Given this list of marker genes FHL1, CKB, CYTH1, HECA, BABAM2, VEGFA, UCK2, CD55, PLIN2, RNF19A, SINHCAF, RYBP, YWHAH, DBI, PHYH, CYP39A1, ARID1A, ITGA2, INPP5A, SSBP2, CMC4, CH25H, KCNJ12 (potassium inwardly rectifying channel subfamily J member 12), PROS1, GAB2, DIAPH2, PTPRF, NELL2, SHB, RAPGEFL1, LIMA1, DBF4, PACSIN2, TACC2, KAT6B, DSG3, SUCO, ID4 (NCBI Gene Id 3400), GAS6, ZBTB11, SLCO3A1, DCP1A, OPN3, PRC1, E2F6 (NCBI Gene Id 1876), HDAC5, SPTAN1, UNG, DAPK3, SNAI2, DGCR6, OXSR1, HBA1, CSNK2A2, MXD1 (NCBI Gene Id 4084), RNF4, CYP4F12, BCL11B (NCBI Gene Id 64919), TESK2, SLC22A18, CLIC3, PKIA, CHORDC1, CTPS1, GATM, EPHB6, PDGFC, IRF8, PTGS2 (NCBI Gene Id 5743), CYP27B1, PER3, PTPN21, PBXIP1, RHOB, AREG, TDG, RSU1, GAN, EIF4G3, KLF11, SOS2, RAB40B, EML2, GSTA4, PLXNA2, FRY, RLF, SLCO4A1, GALC, TBK1, PITPNB, CUTA (cutA divalent cation tolerance homolog), HSPB1, SMNDC1, ABCD3, BCHE, CPM, LGALS3, EML1 (EMAP like 1), SCARB1, SCEL, CADM1, LEMD3, STXBP1, KLF2, DNASE2, DHX8, SH3GLB2, PTPRA (protein tyrosine phosphatase receptor type A), CXCL14, FZD7, CTSF, UBAP1, DBP, SRD5A1, CLCA4, WNT4, LY6G6C, RPS6KA5, RPS6KA3, GOLPH3, RAI14, NDRG1, TSC2, CFD, PRKCH, PLLP, PDCD4, SLC6A9, NDEL1, TUBA1A, HOOK1, VPS45, MMP3, GNAI1, TLE3, IVL, TRAF6, NOP53, CTSV, CTSH, FBXW2, FCGBP, C1orf21, BRD3, FAM117A, ACSL1, DDX21, UPK1A, HS3ST1, CCL22, GBP2, FKBP8, FZD10, RCAN1, ERP29, EGR1, MATN2 (matrilin 2), HSD17B4, FILIP1L, ALAD, PEX13, TNFAIP3, CYP2C18, KRT17, CLEC2B, STX11, WDR1, PDE4B, EGR3, RIPK4, MPZL2, TRIM16, UGCG, TPPP3, SYNCRIP, DNAJB4, SPTBN2, LZTFL1, MYO6, F3, ISG20, GNL2, GPT, ZNF331, CRY1, PIK3CB, STK17B, ZBTB16, PMP22, TULP4, VPS41, HSPH1, DNAJB6, PNP, GSTA3, EPHA2, PTBP3, DNAJB1, LXN, EZR, PELI1, HERC2, GSN, GNA15, SEMA4D, CRIP1, PIM1, DUSP10 (dual specificity phosphatase 10), NAMPT, SMAD7, TECR, DNM1, PRSS23, CLPX, PPAN, CYP4B1, RNASET2, MSRA, PANX1, TFRC, CDC5L, NDUFS4, HSF2, HSPA1A, PNRC1, APC, PTGER4, TGFBR3, IRF6, NR4A2, CHP2, FYN, NBR1, PRDX2, CIRBP, THAP12, MED4, PLD1, UBL3, ROBO1, FOSL1, COL5A3, PLAU, EEF1A2, HK2, NFIB, LPP, EXT1, SPRY2 (sprouty RTK signaling antagonist 2), ATF6, EMP2 (NCBI Gene Id 2013), DCK, HIF1A, VIPR1 (vasoactive intestinal peptide receptor 1), PLAUR, KPNA4, UNC119, ATP7A, MGST3, HOMER1, SLC2A4RG (SLC2A4 regulator), ANXA9, NOD2, BEX3, STAM, ID3, MED17, GATA3, UTRN, ACSBG1, F2RL1, ZFP36L2, S100A2, SLC7A5, PWP2, NPAT, SPON2, AK6, IRS2, JARID2, ERF, SULT2B1, CD207, TIGAR, SCNN1B, PKIG, CTNNBIP1, HSD11B1, ADH6, ZNF217, FAM8A1, ELF4, PBX3, ATP2B1, MT1X, PLPP1, ATXN7, MRPS30, SPAG9, NECTIN2, PNO1, SELENOP, RORA, HPGD, SLC1A6, CHIC2, PPP2CA, DUSP2, AQP3, DUSP6, IL20RA, GMEB1, PELI2, HIVEP2, ATF3, CDK7, IL1R2, ADM, CLDN1, EFS, KMT2A, GPR87, EGLN1, TESK1, COL7A1, FJX1, SLC20A1, DDX10, RACGAP1, DNASE1L2 (NCBI Gene Id 1775), TRPS1 (NCBI Gene Id 7227), RAB4B, PCBP2, EPHX2, ITM2A, LSP1, PLAGL1, IVNS1ABP, LRRFIP1, ST14, FOSB, RAB22A, UAP1, KRT6A, CRLF3, B4GALT5, EHF, SKAP2, LSS, PSMB9, HLF, BDH2, KCNK7, TP53BP2 (tumor protein p53 binding protein 2), ALDH3A1, F2R, SPINK5, MAT2A, ARG1, DNTTIP2, NFATC1, ADAP2, APOE, CORO1C, APOOL, PRKCD, BTBD2, TGFBI, ODC1, KATNA1 (NCBI Gene Id 11104), IL37, HEBP1, MARCHF6, GJB3, IL6R, IMPA2 (NCBI Gene Id 3613), BCL10, TCF4, SART3, LCE2B, RPS6KA2, NCOA1, THBD, ABCC3, NEBL, HSPB8 (NCBI Gene Id 8097), BCL3, UBE2H, STX8, NEO1, LIN7B, B3GNT2, RTN3, ITGAV, CYP2J2, TMEM50B, ACAT1, FOXN3, ITPRID2, ARL4C, GUSB, ZNF277, MAP3K8, BCL11A, BTN3A3, CD83, ELL2, SCPEP1, GALNT2, CEMIP2 (NCBI Gene Id 23670), DDAH1, IL4R, TNFRSF10B, TXNRD1, TRIB1, MAP2K3, FSCN1, GTPBP4, NFATC3, RNPS1, ENTPD7, ATF5, PON2, ANG, SATB1, ANXA1, NCOR2, EMP1, KRT16, NXT1, PFKFB3, GLRX, GNA13, GPR183, SH3BGRL, SAP30BP, BBOX1, DNAJB2, PHGDH, NUFIP1, PPP3CA, MGMT, FHL2, CCL20, TGFA (NCBI Gene Id 7039), FGFR2, ZNF26, ATF6B, RRP1, QDPR, DNAJC1, NAP1L1, PRKCB, DHCR24, DCXR, POSTN, PIGA, FEM1B, KLF3, PIGN, SIRT1, GSPT1, CCND1, HERC1, S100A4, SH2D3A, RPS6KB1, KCNK1, INTS6, CDH3, MAPKAPK2, ABCC4, AZGP1, UVRAG, AFF4, ASAH1, ADAMTS1, VAV3, BNC1, KDM6A, ASS1, EIF2D, DKK3, TPD52, YAP1, DUSP8, RPL31, ZNF207, MAP4K5, TIMP2, USP3, MBTPS1, INSR, CXCL2, ARHGAP29, PPP2R2A, DLG1, OCA2, ALDH2, EIF2AK3, RAB5A, ERBIN, PRDM2, IL36G, KIT, ABR, IGFBP3, CDKN1C, BMAL1, CSNK1D, CBX4, here is a description of the gene set: In order to obtain a comprehensive picture of the molecular events regulating cutaneous photodamage of intact human epidermis, suction blister roofs obtained after a single dose of in vivo ultraviolet (UV)B exposure were used for microarray profiling. We found a changed expression of genes. Half of the UVB-regulated genes had returned to pre-exposure baseline levels at 72 h, underscoring the transient character of the molecular cutaneous UVB response. Of special interest was our finding that several of the central p53 target genes remained unaffected following UVB exposure in spite of p53 protein accumulation. We next compared the in vivo expression profiles of epidermal sheets to that of cultured human epidermal keratinocytes exposed to UVB in vitro. We found genes that differed in their expression profiles between the two groups. The expression profile in intact epidemis was geared mainly towards DNA repair, whereas cultured keratinocytes responded predominantly by activating genes associated with cell-cycle arrest and apoptosis. These differences in expression profiles might reflect differences between mature differentiating keratinocytes in the suprabasal epidermal layers versus exponentially proliferating keratinocytes in cell culture. Our findings show that extreme care should be taken when extrapolating from findings based on keratinocyte cultures to changes in intact epidermis. from publication Enk CD, Jacob-Hirsch J, Gal H, Verbovetski I, Amariglio N, Mevorach D, Ingber A, Givol D, Rechavi G, Hochberg M (PMID 16434974) species: Homo sapiens Human Gene Set: ENK_UV_RESPONSE_EPIDERMIS_DN Genes down-regulated in epidermis after to UVB irradiation.